The following is a description of a gene set: Genes down-regulated in comparison of naive CD4 T cells versus stimulated CD4 Th1 cells at 48 h. species: Homo sapiens Human Gene Set: GSE22886_NAIVE_CD4_TCELL_VS_48H_ACT_TH1_DN Immune cell-specific expression is one indication of the importance of a gene's role in the immune response. In order to identify such patterns, we set out to broadly profile gene expression in a variety of immune cells. from publication Abbas AR, Baldwin D, Ma Y, Ouyang W, Gurney A, Martin F, Fong S, van Lookeren Campagne M, Godowski P, Williams PM, Chan AC, Clark HF (PMID 15789058), and this is the list of marker genes: H3C8, BATF, TBC1D10B, MCM3, CENPC, CDK7, COX8A, CCNF, FADD, PSMA6, RACGAP1, MYL6B, P4HA2, WRAP53, GPR19, KCTD5, RTCB, CCDC51, PRDX1, COX17, POP4, FAH, RAD51, H2AZ1, CYC1, PFKP, BIRC3, TUBB6, SLIRP, CLDND1, KLHL5, SNRPD3, MTHFD2, KDM4D, CCNB2, ZNF593, ATP5PB, TUBB, MRPL58, GMNN, TARDBP, RRM1, KIFBP, ELL2, EIF3I, RNF34, ARFIP1, PDHA1, CTNNAL1, ARPC5, KNTC1, PSMC2, SNRPB, MCAT, MT1E, SNRPA1, COX6A1, HTATIP2, STARD7, PRDX3, EIF2S1, ATP2A2, DCPS, DPAGT1, DONSON, SGCB, EIF2B2, BCL2L1, FKBPL, SLC35F2, NDUFB3, PIMREG, SMTN, HNRNPA2B1, ACOT7, PSMD14, CIAO2B, YWHAE, PKMYT1, CAPRIN1, MTCH2, NDUFV1, RFC3, ERCC1, PELO, STIP1, POLR2E, CDK2, KLHL7, ENY2, HSPA9, PARK7, IDH1, PSMD8, GCNT1, CNOT6, GABPB1, RIT1, HMBS (NCBI Gene Id 5448), PSMB3, CENPU, FAR2, ITGAE, PITPNB, PSMD1, NDUFS3, UBE2S, SMC4, ETFA, USP1, COPS4, MFAP1, GGCT, PNP, GTF2A2, SEPHS1, MRPL35, FOCAD, BUB1, BMAL2, NUP62, IMMT, LSM3, SDC4, MNAT1, SLCO4A1, PPP1R10, ERAL1, ORC6, EIF4G1, H2AX, CMAS, CKS1B, GALK1, UBE2I, CSTF2, ASF1A, HMGB2, NUP107, MACIR, CPOX, EID1, GINS2, FASTKD3, MRPL17, GGH, PSMA1, GIGYF2, CHCHD2, PPIA, LSM4, THYN1, ATOX1, U2AF1, GARS1, MRPL13, ERLIN1, STAMBP, GNPAT, ATG101, EXO1, UQCRH, VDR, GOLT1B, MRPL18, ENPP2, NDUFAF3, TRIP12 (thyroid hormone receptor interactor 12), GLRX2, PSMD2, ELAVL1, MPDU1, NDUFS1, MRPL22, DIABLO, EDC3, POLE, MSMO1, RUVBL2, HTRA2, TPI1, PSMA4, SNX5, PSMB8, CTPS1, TMCO1 (NCBI Gene Id 54499), MICAL2, HIGD1A, SNRPE, ERI2 (ERI1 exoribonuclease family member 2), ZWINT, MED7, MCM5, CYP1B1, HAT1, ALDH18A1, IFT25, SNRPD1, PSMG2